Given this list of marker genes FOXE3, FBN1, ROBO4, MYLK, MYH11, THSD4, SMAD2, NKX2-5, GNB2, TGFB3, SMAD6, LOX, SMAD3, GATA5, SMAD4, TGFB2, EMILIN1, ACTA2, TGFBR1, ELN, HEY2, MFAP5, PRKG1, COL3A1, TGFBR2, NOTCH1, MAT2A, here is a description of the gene set: species: Homo sapiens Any structural anomaly of the portion of the aorta that arises from the base of the left ventricle and extends upward to the aortic arch and from which the coronary arteries arise. Human Gene Set: HP_ABNORMAL_ASCENDING_AORTA_MORPHOLOGY Abnormal ascending aorta morphology